Given this list of marker genes ACTG1, SPTAN1, SCN7A, L1CAM, ANK3, SCN3B, SCN10A, ANK2, SCN2B, SPTBN1, SPTBN2, SPTBN4, SCN2A, KCNQ3, SCN9A, NFASC, SCN5A, SCN8A, ACTB, SCN4B, KCNQ2, SCN1B, SPTA1, SPTB, SCN4A, NRCAM, SCN1A, SCN11A, SCN3A, ANK1, SPTBN5, here is a description of the gene set: Human Gene Set: REACTOME_INTERACTION_BETWEEN_L1_AND_ANKYRINS species: Homo sapiens Interaction between L1 and Ankyrins